Given this list of marker genes BCAR1, MED1, NRP1, CASR, CRIPTO, ADAMTS12, VIL1, APPL1, CREB1, IL10, RELA, GCLC, CRK, LGMN, APPL2, GCLM, HGF, here is a description of the gene set: Any process that results in a change in state or activity of a cell or an organism (in terms of movement, secretion, enzyme production, gene expression, etc.) as a result of a hepatocyte growth factor stimulus. species: Homo sapiens Human Gene Set: GOBP_RESPONSE_TO_HEPATOCYTE_GROWTH_FACTOR